The following is a description of a gene set: Genes in the cancer module 196. Human Gene Set: MODULE_196 studied in species Homo sapiens, and this is the list of marker genes: KIF11, KIF14, KIF23, STMN1, DYNC1LI2, KIF5C, MAPRE1, KIF5A, DYNC1I1, DCTN2, ADRB2, TUBB4B, MAP2, TUBB3, CENPE, DYNLL1, DNM1, MAP1B, SNTB2, KIF2C, ARSB, TUBA4A, KIF3B